The following is a description of a gene set: Binding to a platelet-derived growth factor receptor. studied in species Mus musculus Mouse Gene Set: GOMF_PLATELET_DERIVED_GROWTH_FACTOR_RECEPTOR_BINDING, and this is the list of marker genes: Pdgfra (platelet derived growth factor receptor, alpha polypeptide), Pten, Pdgfd, Ptprj, Vegfa, Pik3r1, Rasa1, Pdgfc, Lyn, Pdgfrb, Ern1, Pdgfb, Il1r1, Pdgfa